The following is a description of a gene set: Any process that results in a change in state or activity of a cell (in terms of movement, secretion, enzyme production, gene expression, etc.) as a result of a double-stranded RNA stimulus. studied in species Homo sapiens Human Gene Set: GOBP_CELLULAR_RESPONSE_TO_DSRNA, and this is the list of marker genes: STING1, MAVS, RALB, P2RX7, RIGI, CGAS, IFIH1, IRF3, NFKB1, CAV1, NPM1, OAS1, GRIA1, IFNB1, OAS3, PQBP1, FLOT1, COLEC12, RIOK3, MUL1, IFIT1, PDE12, ZCCHC3 (zinc finger CCHC-type containing 3), TLR3, DHX9